Given this list of marker genes TMX3, TET1, SAC3D1, VAPA, ZNF674, MMP7, SEC16B, RANBP6, FAM124A, EFCAB7, CPSF6, RAP2C, ELMOD1, NOL4L, UBR3, DHX15, RIPOR2, RNF170, SEMA6D, SPCS2, FERMT2, ZNF385A, RASA2, PARPBP, APPBP2, AKAP5 (NCBI Gene Id 9495), PHLDB1, ARHGAP42 (Rho GTPase activating protein 42), RFFL, AMMECR1, PITPNC1, PSMD9, FHIP2A, TM9SF2, GPR82, SET, RAP1GDS1, HOXC4, CCNL1, GCSH, OTULINL, RTP4, SLC18A2, GSG1, ATP6V1D, ENSG00000255537 (NCBI Gene Id 403312), BNC1, PDE1B (phosphodiesterase 1B), HIPK3, ITGA3, TMEM181, here is a description of the gene set: from publication Chen Y, Wang X (PMID 31504780) species: Homo sapiens Human Gene Set: MIR7153_3P Genes predicted to be targets of miRBase v22 microRNA hsa-miR-7153-3p in miRDB v6.0 with MirTarget v4 prediction scores > 80 (high confidence targets).